Given this list of marker genes Cct7, Cct8, Cct2 (NCBI Gene Id 12461), Cct5, Cct4, Cct3, Tcp1, here is a description of the gene set: studied in species Mus musculus The process of assisting in the correct noncovalent assembly of posttranslational proteins and does not depend on additional protein cofactors. This function occurs over one or more cycles of nucleotide-dependent binding and release. Mouse Gene Set: GOBP_CHAPERONE_MEDIATED_PROTEIN_FOLDING_INDEPENDENT_OF_COFACTOR